Given this list of marker genes FBXO28, POLR3GL, NSD1, APC2, ZNF407, FBXO11, here is a description of the gene set: Human Gene Set: HP_BILATERAL_CAMPTODACTYLY species: Homo sapiens Bilateral camptodactyly